Given this list of marker genes TLR4, FGA, FGG, TLR6, HMGB1, CD36, CD14, TIRAP, FGB, TLR1, MYD88, S100A9, S100A1 (S100 calcium binding protein A1), IRAK4, S100A8, BTK, LY96, TLR2, here is a description of the gene set: IRAK4 deficiency (TLR2/4) studied in species Homo sapiens Human Gene Set: REACTOME_IRAK4_DEFICIENCY_TLR2_4